The following is a description of a gene set: Genes down-regulated in monocyte-derived dendritic cells: control versus HIV and SIV infection. Human Gene Set: GSE22589_HEALTHY_VS_HIV_AND_SIV_INFECTED_DC_DN from publication Manel N, Hogstad B, Wang Y, Levy DE, Unutmaz D, Littman DR (PMID 20829794) Dendritic cells (DC) serve a key function in host defense, linking innate detection of microbes to the activation of pathogen-specific adaptive immune responses. Whether there is cell-intrinsic recognition of HIV-1 by host innate pattern-recognition receptors and subsequent coupling to antiviral T cell responses is not yet known. DC are largely resistant to infection with HIV-1, but facilitate infection of co-cultured T-helper cells through a process of trans-enhancement. We show here that, when DC resistance to infection is circumvented, HIV-1 induces DC maturation, an antiviral type I interferon response and activation of T cells. This innate response is dependent on the interaction of newly-synthesized HIV-1 capsid (CA) with cellular cyclophilin A (CypA) and the subsequent activation of the transcription factor IRF3. Because the peptidyl-prolyl isomerase CypA also interacts with CA to promote HIV-1 infectivity, our results suggest that CA conformation has evolved under opposing selective pressures for infectivity versus furtiveness. Thus, a cell intrinsic sensor for HIV-1 exists in DC and mediates an antiviral immune response, but it is not typically engaged due to absence of DC infection. The virulence of HIV-1 may be related to evasion of this response, whose manipulation may be necessary to generate an effective HIV-1 vaccine. species: Homo sapiens, and this is the list of marker genes: MFSD11, HBP1, BORCS6, TACC1, TNKS2, NADK2, RPRD1B, TMEM97, KPNB1, PRKCH, TOLLIP, ACVR2A, COMMD9, FAM53C, MRPS6, PROCR, SLC25A14, DEXI, POLA1, AGL, TERF2IP, KITLG, MAP4K4, MAD2L1BP, PCNX4, SDHC, CFAP141, SPAST, INPP5A, VIRMA, SYAP1, BCO2, MED27, B3GALNT1 (NCBI Gene Id 8706), TAF3, LCLAT1, CCAR1, DIDO1, PPCS, COPG2, RPL4, TIMM29, MTMR9, PPP4R3A, TMEM65, SLC16A1, MED18, ATP6V0C, FRS2, FUS, CBR3, NECTIN3, SAP30L, HIPK1, RNF167, NUS1, TMEM87A, MAP3K20, MOG, SLC19A2, CCDC120, LTN1, MTX3, SMCO4, LINC01160, ALG10, TTC1, SPRTN, DNAJB11, FBXL15, KIAA1958, MAP2K3, CASD1, PRKX, CDC45, DFFB, ZBTB26, MAF1, TNFRSF12A, INTS13, ALG11, PSMD2, OSBPL9, UBE2A, OTUD7B, ANO6, CCDC186, SNX18, WIPI1, ZFTA, HMG20A, CGRRF1, MRPL45, MXD4, BCAP31, SMCR8, KIF18A (kinesin family member 18A), TMEM170B, RMDN3, CHCHD7, TEX264, FGD6, CGGBP1, ZDHHC7, GALNT3, C6orf120, HS2ST1 (NCBI Gene Id 9653), SMG8, ABL2, MAPRE2, MGAT1, OTUD1, MTHFD1L, ANXA11, PSME3IP1, PTPRJ, KLHDC10, PRKAG2, MAGED1, MBNL2, GXYLT1, UTP4, DNTTIP2, GPAT3, HCFC1, DPH2, TXNRD1, C4orf46, RAB6A, ZBTB43, RAP2A, CLDN15, CBLB, ANXA2, ABHD5, MAP3K7, PLEK2 (NCBI Gene Id 26499), LATS2, SCO1, NNT, RASL11B, PURB, TMED4, SLC38A1 (solute carrier family 38 member 1), PDGFA, FOXJ3 (forkhead box J3), OAF, IMMT, PURG, ATF7IP, CHKA, TAX1BP3, ZNF319, NCOA1, USP31, DESI1, IRGQ, NF1, FLCN, THAP1, RND3, ZKSCAN3, SETD1B, IDH2, PITRM1, ELMOD2, C5orf34, SLU7, DENND5A, CENPJ, NOA1, NUDT15, UBE4B, NRDE2, TMTC3, MYB, ITPA, ARHGAP35, ELK4, PTGS2, LAMC3, NRM, MMGT1, EXO1, RPN2, JADE2, ABHD3, CIR1, PPP1R8, ZFTRAF1, VPS35L, PHF23, SKP2, DNAAF5, TRIM44, ABRAXAS2, CXCL10, DMRT3, CSDE1, CDC6 (NCBI Gene Id 990)